Given this list of marker genes Morc3, Thap1, Magea5, Kat6a, Eif4enif1, Atr, Rnf6, Elf4, Hipk1, Tenm2, Lrch4, Park7, Smc6, Max, Slf2, Tdp2, Trim16, Rdm1, Chek2, Usp7, Rgs14, Mlip, Wdfy3, Sumo2, Rpa1, Rb1, Spn, Nr2c1, Mtor, Atrx, Trp53inp1, Pml, Pias4, Daxx, Nbn, Bmal1, Top3a, Skil, Magea4, Eif3e, Magea3, N4bp1, Casp8ap2, Pten, Ciart, Hira, Ubn1, Hipk2, Nsmce2, Simc1 (NCBI Gene Id 319719), Satb1, Rad51, Smc5, Sptbn4, Akap8l, Magea10, Trp53, Rpain, Calcoco2, Agap3, Topbp1, Klhl20, Rnf111, Nfe2, Rpa2, Ciita, Mknk2, Blm, Topors, Magea2, Hmbox1, Sp100, Tert, Chfr, Pias2, Cbx5, Rfwd3, Ankrd2, Pias1, Zmym2, Ski, Chd3, Zbtb16, Lrrc28, Trim27, Dapk3, Mapk7, Ikbke (inhibitor of kappaB kinase epsilon), Sirt1, Zfp451, Patl1, Csnk2a1, Sp3, Tdg, Senp2, Rnf4 (NCBI Gene Id 19822), Sumo3, Hsf1, Sumo1, Basp1, Csnk2b, Isg20, Sqstm1, Cdk9, Ppargc1a, Mre11a, Rere, Crebbp, Ube2i, Hipk3, Trp53inp2, Trim8, Zcchc12, Tcf7l2, here is a description of the gene set: species: Mus musculus Mouse Gene Set: GOCC_PML_BODY A class of nuclear body; they react against SP100 auto-antibodies (PML, promyelocytic leukemia); cells typically contain 10-30 PML bodies per nucleus; alterations in the localization of PML bodies occurs after viral infection.